Given this list of marker genes HAS2, DDX39A, NUP88, FOXM1, PKMYT1, HMGN2, CCNF, MCM2, HMGB2, MCL1, CDC25B, PARP1, KIF2C, CENPA, SAFB (scaffold attachment factor B), PTGS2, UGCG, CBX1, TYMS, ENPP2, H2AX, NASP, CKS1B, MYBL2, MMP3, CXCL8, BARD1, FBL, SERPINB2, RANBP1, here is a description of the gene set: Genes down-regulated in fibroblasts from patients with Hutchinson-Gilford progeria (premature aging), compared to those from normal young individuals. studied in species Homo sapiens Messenger RNA levels were measured in actively dividing fibroblasts isolated from young, middle-age, and old-age humans and humans with progeria, a rare genetic disorder characterized by accelerated aging. Genes whose expression is associated with age-related phenotypes and diseases were identified. The data also suggest that an underlying mechanism of the aging process involves increasing errors in the mitotic machinery of dividing cells in the postreproductive stage of life. We propose that this dysfunction leads to chromosomal pathologies that result in misregulation of genes involved in the aging process. Human Gene Set: LY_AGING_PREMATURE_DN from publication Ly DH, Lockhart DJ, Lerner RA, Schultz PG (PMID 10741968)